The following is a description of a gene set: Mouse Gene Set: GOMF_3_BETA_HYDROXY_DELTA5_STEROID_DEHYDROGENASE_NADPLUS_ACTIVITY species: Mus musculus Catalysis of the reaction: a 3-beta-hydroxy-Delta(5)-steroid + NAD+ = a 3-oxo-Delta(5)-steroid + NADH + H+. Also acts on on 3-beta-hydroxypregn-5-en-20-one to form progesterone., and this is the list of marker genes: Hsd3b3, Hsd3b2, Hsd3b6, Hsd3b1, Hsd3b4, Hsd3b8, Hsd3b5, Hsd3b9